Given this list of marker genes IGKV5-2, IGLV4-60, IGHV3-11, IGLC7, IGLV2-14, HCK, IGLV4-3, IGHV1-69, IGHV1-46 (immunoglobulin heavy variable 1-46), IGKV2D-28, IGHV3-53, IGKV3-20, IGLV7-46, LYN, IGKV2D-40, FCGR2A, IGLV5-45 (immunoglobulin lambda variable 5-45), IGLV8-61, IGKV1-39 (immunoglobulin kappa variable 1-39), IGLV3-19, IGKV2-28, IGLV1-51, IGHV, IGKV1-33 (NCBI Gene Id 28933), IGLV3-22, IGLV2-23, IGLV1-36, IGLV1-44, IGKV1D-12, IGHV3-48, YES1, IGLV3-1, IGHV3-30, IGHG4 (immunoglobulin heavy constant gamma 4 (G4m marker)), IGKV1D-16, IGHV3-33, IGLV5-37, IGLC2, IGHV3-7, IGLV3-21, IGLV2-18, IGHV4-34 (NCBI Gene Id 28395), IGLV, IGKV1-16, FCGR3A, FGR, IGLV3-16, IGHV2-70, IGLV4-69, FYN, IGHV7-81 (NCBI Gene Id 28378), IGKV1D-33, IGHV1-2, IGHV3-9, IGLC3, IGHV4-59, IGHG2, IGHV4-39, IGLV2-33, IGKV1-17, IGLV2-8, SYK, SRC, IGHG3, IGKV1D-39, CD247, IGLV1-47, IGKV2D-30, IGLV10-54, FCGR1A, IGKV3-15, CD3G, IGKV2-30 (immunoglobulin kappa variable 2-30), IGLV3-25, IGKV1-12, IGKV2-29, IGLV11-55, IGKV3-11, IGHV3-13, IGHV3-23, IGLV6-57, IGLC1, IGHG1, IGLV3-12, IGLV3-27, IGKV4-1, IGLV2-11, IGKC, IGLC6, IGKV1-5 (NCBI Gene Id 28944), IGLV1-40, IGHV2-5, IGKV3D-20, IGLV7-43, here is a description of the gene set: Reactome Pathway: FCGR activation Cross-linking of FCGRs with IgG coated immune complexes results in tyrosine phosphorylation of the immuno tyrosine activation motif (ITAMs) of the rececptor by membrane-bound tyrosine kinases of the SRC family. The phosphorylated ITAM tyrosines serve as docking sites for Src homology 2 (SH2) domain-containing SYK kinase. Recruitment and activation of SYK is critical for FCGR-mediated signaling in phagocytosis, but the exact role of SYK in this process is unclear. Activated SYK then transmits downstream signals leading to actin polymerization and particle internalization. studied in species Homo sapiens part of: Fcgamma receptor (FCGR) dependent phagocytosis